Given this list of marker genes PTPN11, CD86, CD28, FGF6, PIK3R5, GAB1, IRS2, ICOS, VAV1, PDGFRB, PIK3R1, LCK, FGF3, RAC2 (Rac family small GTPase 2), ESR2, NTF4, CD80, FLT3, NRG3, ERBB4, ESR1, NTRK2, SRC, KL, FGF16, NRG4, FYN, FGF8, MET, PDGFB, BTC, FLT3LG, FGF20, NTRK3, KITLG, RHOG, TGFA, NRG1 (neuregulin 1), FGFR2, HGF, BDNF, EREG, PIK3R6, FGFR4, FRS2, STRN, NTF3, CD19, FGF10, EPGN, NRG2, FGF1, FGF2, FGF9, EGFR, PDGFRA, PIK3AP1, PIK3CB, FGF23, GAB2, HBEGF, PIK3CA, ERBB2, IRS1, KIT, FGF19, PIK3CG, FGF4, FGF17 (fibroblast growth factor 17), AREG, PIK3R2, PIK3R3, FGFR3, GRB2, FGF18, RAC1, FGF22, ERBB3, FGFR1, PDGFA, PIK3CD, KLB, TRAT1, FGF7, FGF5, EGF, here is a description of the gene set: Constitutive Signaling by Aberrant PI3K in Cancer species: Homo sapiens Human Gene Set: REACTOME_CONSTITUTIVE_SIGNALING_BY_ABERRANT_PI3K_IN_CANCER